Given this list of marker genes GDF5, CNTF, SHH, WNT2B, FGF8, WNT5A, IL11, PDGFB, INHBA, ALK, CXCR1 (C-X-C motif chemokine receptor 1), TPO, NT5E, FGF2, NOG, WNT2, INS, IGF1, EGF, IL6R, NTF4, HGF, WNT7B, LEFTY1, VEGFA, IL6, TNFSF11, KIT, TF, WNT1, NOTCH1, FGF4, DKK1, FLT3LG, CSF1R, KITLG, FGF10, EPO, PDGFA, CSF1, BMP4, FGF1, TGFB3, IL3, NODAL, FST, TGFB1, WNT3A, here is a description of the gene set: Human Gene Set: WP_PLURIPOTENT_STEM_CELL_DIFFERENTIATION_PATHWAY studied in species Homo sapiens Pluripotent stem cell differentiation pathway